The following is a description of a gene set: Mouse Gene Set: GOCC_SEC61_TRANSLOCON_COMPLEX A translocon complex that contains a core heterotrimer of conserved alpha, beta and gamma subunits, and may contain additional proteins (translocon-associated proteins or TRAPs); in budding yeast the core proteins are Sec61p, Sbh1p, and Sss1p. The Sec61 translocon complex functions in cotranslational and posttranslational translocation events. species: Mus musculus, and this is the list of marker genes: Arl6ip1, Ssr4, Sec61a1, Sec61b, Sec61a2